Given this list of marker genes EFL1, PXYLP1, GK, ETS2, CLTC, GSTO2, GRK3, PTDSS1, CXCL13, GRK4, PMS1, PPA1, HDC, KYAT3, HSD17B6, SERPINB1, SEC11A, YES1, C2orf76, RCL1, RNASEH2B, LINC01281, HMG20A, MRPS15, STAG3, CD2, PRF1, TRAK1, CCDC51, ARHGEF2, SLC7A5, RGS3, ARHGEF7, LRRCC1, VAMP1, BATF3 (NCBI Gene Id 55509), SQLE, BABAM2, MCCC2, CD200, B3GNT5, RAB27A, CENPV, LASP1, DENR, DBN1, MPP1, SOCS6, STMP1, LAT2, PPP2R5A, NAB1, PALLD, NRAS, COX15, BEND5, ZSCAN30, STAMBP, UBE2V2 (ubiquitin conjugating enzyme E2 V2), PAQR6, RPAP2, NEMP2, TNIP3, SLC25A44, MYEF2, ACADM, IFT27, NHS, TMEM135, CACNA2D4, SUOX, ETV6, VWA5A, ARHGEF6, DIXDC1, B3GNTL1, SPTBN1, SIRPG, NR5A2, MAPRE2, SPON2, AHCYL2, SLC35G2, CLDN12, DUS2, NTRK1, ILDR2, SELL, FASN, NOA1, ZFYVE1, PDE7B, ITGAE, MPZL1, PTPN3, DLEU1, TPRG1, VNN2, ABTB3, SLC12A6, UBE2G1, CD27, MYO7B, MCTP2, PDGFA, SLC9B2, CASP9, TRIM25, SLC15A4, BSPRY, TXNDC17, MGST2, PRPF6, ITCH, AP2B1, RGL4, GFI1, CHSY1, SLC16A5 (solute carrier family 16 member 5), FAM210A, ACSL3, QSOX2 (NCBI Gene Id 169714), METTL13, MYB, NDFIP2, DECR1, BTBD3, IFT74, PTPN14, GNA12, COX10, NME7, FGGY, CD38, SIAH2, CTTN, CHRNA6, SLC5A3, PI4K2A, FDX1, AGPAT5, TARBP1, BPNT2 (NCBI Gene Id 54928), STK26, NBAS, OSBP2, ATP8B3, CCR7, KCNK5, FASLG, TCEA2, ADAT2, RHOBTB3, RPRD2, CPSF6, NFATC3, CNIH1, AIF1, GRAMD4, EGR1, YWHAQ, HIBADH, ASCC1, DHCR24, CDK5, RAB33A, ELP5, LANCL2, COL6A3, DHTKD1, RUBCNL, TENT4B, SPRY1, GEM, APOLD1, SEC31B, VPS8, CREB3L4, GZMH, MOK, SPA17, NT5C2, LINC01588, CPPED1, CHMP5, CCKAR, SSBP2, PTGFRN, SOX4, MOB1B, SLC39A14, GFOD1, MRPS6 (NCBI Gene Id 64968), DNAH14, INTS6L, DYNLL1, NREP, ATP8A1, here is a description of the gene set: species: Homo sapiens from publication Bangs SC, Baban D, Cattan HJ, Li CK, McMichael AJ, Xu XN (PMID 19201849) Human Gene Set: GSE13738_TCR_VS_BYSTANDER_ACTIVATED_CD4_TCELL_UP Genes up-regulated in comparison of directly activated CD4 T cells versus bystander activated CD4 T cells. There is much evidence that T cells may be activated via mechanisms which act independently of direct TCR ligation. Despite this, the question of whether such forms of ‘bystander’ T cell activation occur during immune responses is hotly debated. To address some outstanding questions, we set up an in vitro system within which to analyse bystander T cell activation in human T cells, in the absence of the possibility for TCR cross-reactivity. In addition, we have investigated the genetic, phenotypic, and functional characteristics of bystander activated T cells. Here, we show that bystander T cell activation is, indeed, observed during a specific immune response, and that it occurs preferentially amongst CD4+ memory T cells. Furthermore, bystander activated T cells display a distinct gene expression profile. The mechanism for bystander T cell activation involves soluble factors, and the outcome is an elevated level of apoptosis. This may provide an explanation for the attrition of T cell memory pools of heterologous specificity during immune responses to pathogens such as viruses.